The following is a description of a gene set: Secondary growth hormone deficiency species: Homo sapiens Human Gene Set: HP_SECONDARY_GROWTH_HORMONE_DEFICIENCY, and this is the list of marker genes: TERT, GLI3, AIP, SMO, SUFU, CDH23, TRAF7, MEN1 (menin 1), SMARCE1, SMARCB1, BAP1, AKT1, NF2, PDGFB, PIK3CA